The following is a description of a gene set: Any process that modulates the frequency, rate or extent of the directed movement of a protein into, out of or within a cell, or between cells, by means of some agent such as a transporter or pore. studied in species Homo sapiens Human Gene Set: GOBP_REGULATION_OF_PROTEIN_TRANSPORT, and this is the list of marker genes: NMU, EFCAB7, GCC2, APOD, CFTR, PLA2G6, ABCG1, PRKCB, IL12B, SLC9B2, NDUFAF2, SLC30A8, PFKFB2, NEO1, SEPTIN8, PRKAR1A, CDKN2A, CLN3, XPO4, CDK1, NDEL1, PKDCC, CHP2, NDFIP1, IL12A, SLC2A2, TENM1, CWH43, CRYZL2P-SEC16B, UBE2G2, ARF6, PIM3, IL1B, ANP32B (NCBI Gene Id 138551), SLC16A1, AACS, TRH, CHRM1, PFKM, SOX4, EPM2A, G6PC2, C1QTNF3, GPR68, PRKCA, SCFD1, SLC35D3, B3GAT3, APBB3, ABCA12, MYO18A, SRI, CAMK1, MYRIP, ADIPOQ, VSNL1, MIR199A1, ZPR1, C1QTNF12, PRR5L, UHMK1, BMP4, EMD, RUFY3, IGF1, PTPN14, HDAC3, HSP90AA1, NNAT, FKBP1B, VPS28, KRT20, CEP290, MIR93, TMED10, MAPK14, RBP4, JAK2, PDE8B, LYPLA1, HSPA8, NR1H3, FOXA2, ECT2, SSTR5, GNAO1, MIR766, CASR, STXBP4, ABCC8, LRRC8A, MIR19A, MIDN, RIPOR1, GCG, DRD2, ISL1, TLR4, FFAR2, TARDBP, TFAP2B, BLK, LEP, YOD1, PRKCE, GIPR, CD33, GRIPAP1 (NCBI Gene Id 84538), NF1, ICE1, PER2, TCIRG1 (T cell immune regulator 1, ATPase H+ transporting V0 subunit a3), SIRT3, CHGA, RAPGEF3, PLCB1, CRH, GHRL, F2, NOS2, KCNA5 (potassium voltage-gated channel subfamily A member 5), EFNA5, RSAD2, ERP29, HADH, ZC3H12A, GNAS, GNA11, BARD1, CAPN10 (calpain 10), DOC2B, PDX1, RAB11A (NCBI Gene Id 8766), SLC8B1, UBR5, GHSR, UCP2, ADORA2A, ENSA (NCBI Gene Id 51620), MPC2, INS, SORL1, OPRM1, DPH3, FLNA, C2CD2L, SFN, RBM22, JUP, PPARG, DERL3, RHBDF2, IER3IP1, PKIA, FRAT2, ACSL3, BRSK2, RHBDD3, SYTL4, P2RX7, XBP1, SLC12A2, CNST, ZBED6, YWHAB, ANG, NUP58, ADTRP, NR1D1, ANKRD1, DNAJC1, CPT1A, IL6, NR1H2, SERP1, VAMP4, SAA1, SNX3, FAM76B, SNAP25, PHPT1, PTPN1, FFAR1, PICK1, GAPVD1, GPR27, CD36, GAS6, ARFIP1, SEC16B, TUNAR, HNF4A, GSK3B, OS9, NR1H4, ARHGAP44, MTNR1B, MYH10, CYP51A1, RACK1, PPIA, CLOCK, SERGEF, FOXO1, NR0B2, OAZ1, PRP4K, AKAP5, FUT11, TXN, BAG3, ANGPT1, ADCY5, ARHGEF5, GPLD1, TLR2, EXPH5, CD38, SMO, MLXIPL, PLK3, REST, APBB1, KCNB1, ADAM8, ALOX5, VEGFC, CTDSPL2, CCL5, HMGCR, TMEM30A, PSMD9, TGFB1, EPHA5, NKX6-1, MAVS, DRD4, KLF7, ADAM9, FGA, RSC1A1, DNM1L, CELA2A, RAC1, TM9SF4, RAPGEF4, DRD3, CDH1, RAB11FIP3, TRPM4, HIF1A, UMOD, GNAZ, BAD, GIP, MCU, ABAT, SEC24A, INHBB, ADCY8, RAN, FERMT1, ACHE, MIR19B1, CARTPT, PIK3R1, P3H1, GOLPH3, UQCC2, GCK, APP, IRS2 (NCBI Gene Id 90066), XPO1, SIRT6, ATP2C1, INSIG1, SELENOK, CHP1, CABP1, RANGAP1, HLA-DRB1, SNX12, KCNK16, IDH2, EI24, CDK16 (NCBI Gene Id 5127), ORAI1, JAGN1 (jagunal homolog 1), SIRT4, FGB, GNAI1, RHBDF1, IL13, MIR128-1, WWP2, GLUD1, PPM1A, ENY2, NFKBIA, TREM2, PRKN, GPER1, MDM2, ATP13A2 (NCBI Gene Id 63919), UBAC2, TTN, GOLPH3L, MIR148A, CD2AP (NCBI Gene Id 25916), PCM1, NLGN2 (NCBI Gene Id 57555), PRKACA, FGG, CCN3, SVIP, PTPN11, GPRC6A, BMP6, PIK3R2, PFKL, GLI3, TGFB3, RPH3AL, BSG, KCNJ11, IL1A, TRPM5, PLA2G1B, PRKCD, FRAT1, SUFU, EP300, F2RL1 (NCBI Gene Id 7901), MIR30C1, DYNLL1, ACSL4, FUT10, PCK2, OR51E2, NPFF, KIF20B, CHRM3, ACVR1C, OAZ2, TCF7L2, TMEM30B, CEP131, WLS, TM7SF3, COMMD1, MIR146A, UBE2J1, SYBU, FRMD4A, BCAP31, EDEM2, RFX3, OXCT1, PDCD10, F2R, PKIG, VPS35, PCNT, IFI27, LCP1, HCAR2, APOE, PPM1F, SH3TC2, ADRA2A, TGFB2, SLC51B, IPO5, TSG101, PPID, PARD6A, EDEM1, FAM3D, TRIM28, IFNG, NEUROD1, TRPA1, SLC25A22, CSK, PTPN23, STX1A, UNC13B, HYAL2, ZIC1, PPP3CB, NDFIP2, CD200, CDK5, SP100, ITPR1, ZFAND1 (zinc finger AN1-type containing 1), MDFIC, IRS1, SYT4, PSEN1, GJA5, ERLEC1, PGRMC1, SYT7, OSBP, ADRA2C, YWHAE, RAB29, RFX6, UFM1, SIRT7, MYOM1, RAB8A, BMAL1, LRP5, CPLX1, PPARD (NCBI Gene Id 5467), MIR29B1, STX4, RAB11FIP1, SHH, ASPH, TMEM97, LYPLAL1, VAMP2, SMAD3, TMEM132A, SLC7A11, UCN3, SIDT2, HCLS1, BMP8A, MIR199B, BAIAP3, PRKD1, RAB23, OAZ3, ZDHHC2, TPR, DERL2, TNF, F2RL2, SREBF1, ANO1, DNAJA1, RAP1GDS1, RAB11FIP5, ERGIC3, CD81, ANXA13, KCNN4, PARK7 (Parkinsonism associated deglycase), EIPR1, SUMO1, DMAP1, NADK